The following is a description of a gene set: Human Gene Set: GOBP_PYRIMIDINE_DEOXYRIBONUCLEOTIDE_METABOLIC_PROCESS The chemical reactions and pathways involving a pyrimidine deoxynucleotide, a compound consisting of nucleoside (a pyrimidine base linked to a deoxyribose sugar) esterified with a phosphate group at either the 3' or 5'-hydroxyl group of the sugar. species: Homo sapiens, and this is the list of marker genes: NTHL1, TYMP, NEIL2, TYMS, NT5C, SHMT1, DCTPP1, DUT, UNG, CMPK2, DPYD, OGG1, UPP1, MBD4, NT5M, UPP2, DPYS, TDG (thymine DNA glycosylase), NEIL1, DTYMK, UPB1, TBPL1, DCTD, SMUG1